Given this list of marker genes IQGAP1, BMP4, PIK3CA, GDF2, PAK2, MAPRE3, CALM2, WNT11, GPRC5C, RICTOR (NCBI Gene Id 253260), ERCC6, AGAP2, CKS2, MAP3K20, PARP16, MARK2, CCNB1, CDKN1A, MAP3K13, DBF4, DAXX, CALM3, FERMT2, TOPBP1 (DNA topoisomerase II binding protein 1), CKS1B, ETAA1, LAMTOR3, AJUBA, CD40LG, PRKRA, GPRC5D, AXIN1, GREM1, PDE8A, BTC, PIM1, CD24, MOB3B, DAB2IP, SAV1, ERBB3, ALS2, HBEGF, RHEB, TAOK1, WNK1, ALKAL1, SLC27A1, STK11, STK4, IGF2, CDKN1B (cyclin dependent kinase inhibitor 1B), TCL1B, INSR, CCL5, GDF10, DDX3X, ADIPOQ, BCL10, TGFB1, IL2, EFNA5, GCN1, TGFA, MALT1, ACSL1 (acyl-CoA synthetase long chain family member 1), IRGM (immunity related GTPase M), RAD50, BMP7, ALK, LTF, NRG1, TGFBR2, SRC, MAPK8IP2, DGKQ, MTCP1, CCND2, MAP3K12, DAZAP2, TREM2, DUSP19, NBN, MLST8, SPDYA, EPO (erythropoietin), PARP8, GPRC5A, EPGN, CCND3, STK3, STRADB, MOB1B, VEGFA, BMP2, EGFR (epidermal growth factor receptor), MOB3A, GPRC5B (NCBI Gene Id 51704), SAMD15, NCKAP1L, RPTOR, PRKAG2, MT3, NRG3, CCNT2, MSTN, MOB1A, NGF, GHRL, CDK5R2, ALKAL2, RGCC, AFAP1L2, EEF1A1, DELE1, NEK9, TAB1, ABI1, CCNK, CAB39L, HMGB1, DBF4B, TAOK2, PARP6, ATG13, EGF, TNKS1BP1, HTR2A (5-hydroxytryptamine receptor 2A), ANGPT4, GRM5, MNAT1, CCND1, MAP2K1, CDK5R1, CCDC88A, AREG (NCBI Gene Id 727738), IGF1 (NCBI Gene Id 3479), RANBP2, STRADA, MOB2, MADD, CAB39, FAM20A, MOB3C, SPRY2, RPLP1, TOM1L1, EREG, STAP1, TPX2, ACVR2B, CALM1, GHR, PIK3R1, LTK, MAP2K2, TCL1A, CCNT1, IL6ST, here is a description of the gene set: Binds to and increases the activity of a kinase, an enzyme which catalyzes of the transfer of a phosphate group, usually from ATP, to a substrate molecule. Human Gene Set: GOMF_KINASE_ACTIVATOR_ACTIVITY species: Homo sapiens